Given this list of marker genes AMOTL2, LITAF, POLR1F (RNA polymerase I subunit F), TNFRSF11B, LEPROT, TP53BP2, CLK1 (NCBI Gene Id 1195), TAX1BP3, AGT, NXT2, CLIC4 (NCBI Gene Id 25932), TGFBR2, FGF1, HSD17B6, HEBP2, GIPC1, WNK1, PON2, PLXNC1, MLC1, UBR5, GNG12, BAMBI, ALDH9A1, NFE2L2, ZNF652, CAST, VWF, WFS1, FXYD1, RAP1B, DPYSL3 (dihydropyrimidinase like 3), RASSF2, PRDX6, GNG11, VEGFB, RGS20, CHSY1 (chondroitin sulfate synthase 1), CLASRP, TOPORS, TM4SF1, CBS, MSN, MYOF, HBB, ITPRID2, HEPH, SMC3, FGFR2, RYR1, FADS1, ZBTB20, GPC5, H2AC6, RIN2, RIN1, ADD3, VIM, PTPN13, EFS (embryonal Fyn-associated substrate), LRIG1, TOR1AIP1, RNASE1, ITGAV, TMEM47, CEP170, APOD, PALLD, PDLIM5, PPFIA1 (NCBI Gene Id 8500), CD302, MTRR, KDSR, CRYAB, TNNT1, IFI16, OGG1, PLPP1, ITM2A, SDC2, MT2A, TMEM123, FYN, CFH, TXNIP, RAPGEF4, NUPR1, PLOD2, SSPN, GPR137B, EFEMP1, SCP2, YES1, EYA1, RHOBTB3, PHF3, MT1E, MAOA, NFKBIA, SLC14A1, MT1B, TASOR, GREB1, ZCCHC24, CSRP1, LTBP1, LPIN1, OFD1, TLE4, LPP, IRF7, ANXA3, ZHX2, TMED10 (NCBI Gene Id 10972), PHLPP1, COL4A5, DNASE1L1, PDLIM3, GUSBP14, HNRNPH3, FGF2, TST, PIK3C2A, ACAA2, NKX2-2, PMP22, TOB1, FGFR3, MT1G, ECM2, ERBB3, UNG, RGN, INHBB, CALD1, FRYL, EPM2A (NCBI Gene Id 7957), CLDN5, KANK1, CETN3, TGIF1, TIPARP, SERINC5, EFHD1, ABCD3, MAL, BMP7, SLC4A4, ANP32B, CEBPD, VAT1, MYL12A, RBL2, HTRA1, LRP4, ANXA5, TGM2 (transglutaminase 2), TWF1, SEMA3B, SH3GLB1, CYP1B1, SPTSSA, SERPINH1, IL33, HIF1A, BCL2, HBA1, TCAF1, CLEC2B, NT5C2, PARVA, ICAM2, ABCG1, ALDH4A1, TMT1A, FERMT2, TPD52L2, ZBTB1, STOM, PICALM, ASCL1, HCRTR2, WWTR1, AHCYL2, MAP3K5, CAV1, PTP4A2, AHCYL1, ACTL6A (NCBI Gene Id 9178), SEPTIN4, NIPBL, IQGAP1, AFF1, GNE, GJA1, SMC5, SNAP23, DDIT4 (DNA damage inducible transcript 4), CPNE3, S1PR1, ID4, PECAM1, PODXL, PIP4K2A, STK3, TSC22D4, ELOVL2, NEK7, BAZ2B, HP, OLIG2, SLC16A1, PCF11, MYO10, PAIP2B, SEPTIN10 (NCBI Gene Id 151011), SYPL1, HSPA2, RAMP1, CAV2, GPRC5B, ITGB1, KLC1, VEGFA, GSN, SELENOP, GATM (glycine amidinotransferase), TLN1, NDRG1, MTSS1, IQCK, PLXNB1, SFRP1, AHNAK, NPC1, AMOT, DHRS3, ACSBG1, S100B, VCAN, SPON1, VAMP3, BBOX1, WIPI1, QKI, RDX, MFAP3L, GAB2, DDR1, NTRK2, ADGRA3, PEX1, PDE4DIP, ZEB2, NEBL, GFAP, CLIC2, INSR, ADIRF, PLP1, CREB3L2, LAMP2, ITPKB, ZNF423 (NCBI Gene Id 23090), here is a description of the gene set: Human Gene Set: LU_AGING_BRAIN_UP Age up-regulated genes in the human frontal cortex. The ageing of the human brain is a cause of cognitive decline in the elderly and the major risk factor for Alzheimer's disease. The time in life when brain ageing begins is undefined. Here we show that transcriptional profiling of the human frontal cortex from individuals ranging from 26 to 106 years of age defines a set of genes with reduced expression after age 40. These genes play central roles in synaptic plasticity, vesicular transport and mitochondrial function. This is followed by induction of stress response, antioxidant and DNA repair genes. DNA damage is markedly increased in the promoters of genes with reduced expression in the aged cortex. Moreover, these gene promoters are selectively damaged by oxidative stress in cultured human neurons, and show reduced base-excision DNA repair. Thus, DNA damage may reduce the expression of selectively vulnerable genes involved in learning, memory and neuronal survival, initiating a programme of brain ageing that starts early in adult life. species: Homo sapiens from publication Lu T, Pan Y, Kao SY, Li C, Kohane I, Chan J, Yankner BA (PMID 15190254)